The following is a description of a gene set: Mouse Gene Set: MIR_6917_5P from publication Chen Y, Wang X (PMID 31504780) studied in species Mus musculus Genes predicted to be targets of miRBase v22 microRNA mmu_miR_6917_5p in miRDB v6.0 with MirTarget v4 prediction scores > 80 (high confidence targets)., and this is the list of marker genes: Cdh8, Kdm5a, Syt5, Ubn2, Adora2b, Ptprb, Klhdc1, Scn3a, Tmem245, Zc4h2, Zfp287, Nrn1, Greb1l, Psen1, Sugct (NCBI Gene Id 97907), B3gat2, Inpp5j, Ntrk2, Scnn1a (sodium channel, nonvoltage-gated 1 alpha), Rab18, Mog, Arid4a, Proser3, Map3k9 (NCBI Gene Id 338372), Mphosph8, Pes1, Ntrk3, Nomo1, Marcksl1, Morc3, Pde5a, Mtmr12, Ulk1, Lacc1, Ube2v1 (ubiquitin-conjugating enzyme E2 variant 1), Aplp2, Gpr137, Lrig1, Tmem254, Nagpa, Kpna1, Picalm, Cks1brt, Nrep, Pcdh9, Zdhhc24, Thbs1, Col1a2, Rundc3a, Or4e1, Bcl6b, Rbbp8nl, Pdk3, Lgals12, Pcdh15, Aldh1l2, Trim23 (tripartite motif-containing 23), Shisa3, Nrarp, Gm5878, Esp8, Phox2b, Epc1, Rbm12b2, Creb1 (NCBI Gene Id 98624), Rnmt, Nr2c1, Cd59a, Pbx1, Zdhhc3, Aff4, Maml3, Mcfd2, Mtf1, Arpp19, Irgm1, Dkk3, Ttc23, Adamtsl4, Galk2, Paqr9, Ppp1r3b, Pou3f4, Alg8, Hpn (hepsin), Dnajc5, Cftr, Mef2a, Gnas, Smarca4, 9030624G23Rik, Wwp1, H2-K1, Aldh9a1, Amd2, Isoc1, Fut9, Gabpb1, Plcb1, Secisbp2l, Prr13, Crbn, Atxn1 (NCBI Gene Id 97894), Nusap1, Hnf1b, Kank1, Gpc2 (glypican 2 cerebroglycan), Cndp1, Itga4, Pde1c, Rnf38, Tchh, Klrb1f, Wfdc1, Sike1, Tmem207, Slk, Pctp, Kif13a, Oxr1